The following is a description of a gene set: IL-10 or IL-6 stimulation of control 129xC57BL/6 murine bone marrow derived macrophages in the presence of LPS. We used microarrays to detail the global programme of gene expression changes in response to IL-6 or IL-10 stimulation in the presence of lipopolysaccharide. BMDMs were isolated from control, IL-6-/-, and IL-10-/- mice on a 129XBL/6 mixed background mice and differentiated in the presence of CSF-1 for 6-7 days. Cells were scraped and plated in 6 well plates at 2x10e6/well. Cells were washed with complete DMEM and rested for 1-2 hr before stimulation with combinations of IL-10 (10 ng/ml), IL-6 (2 ng/ml) or LPS (100 ng/ml) for 45 min or 180 mins. Complete biological replicates were performed. species: Homo sapiens from publication El Kasmi KC, Holst J, Coffre M, Mielke L, de Pauw A, Lhocine N, Smith AM, Rutschman R, Kaushal D, Shen Y, Suda T, Donnelly RP, Myers MG Jr, Alexander W, Vignali DA, Watowich SS, Ernst M, Hilton DJ, Murray PJ (PMID 17114459) Human Gene Set: GSE5589_UNSTIM_VS_45MIN_LPS_AND_IL6_STIM_MACROPHAGE_UP Genes up-regulated in bone marrow-derived macrophages: untreated (0 min) versus IL6 and LPS (45 min)., and this is the list of marker genes: INPP4A, PBRM1, TUG1, MOB2, PNISR, SPEN, PHF14, MPST, ZXDC, BACH1, MLEC, IFT25, KLF6, PLPP2, RCBTB2, FILIP1L, PAFAH1B3, TRPS1, DOCK3, MIGA1, PARP3, LRP5, PARP8, LMO2, PIK3CG, NFIA, DYNLT1, PTPRC, KCNJ10, SLC11A1, PIK3IP1, ABTB1, RDH10, SURF4, HPS4, HNRNPUL1, MRPS18C, MTMR14, AMBRA1, PKIB, OLFML3, KLF2, HSCB, ENTPD4, DMXL2, TAL1, SLC6A6, FRY, ING1, ASPSCR1, CIR1, CANX, CYSLTR1, CYTH1, CDC25B, TMEM176B, RNF135, AKNA, KHK, RRM1, PTK2B, SNHG3, RAB32, VPS54, HSDL1, IFT140, SMAD6, WBP1 (NCBI Gene Id 96445), MRPL18, TNFRSF13B, ZFP90, RPL23A, EXOC4, MLF2 (NCBI Gene Id 8079), XPA, CLASP2, SNX20, MCOLN3, ORC3, MRPL39, AGO1, SHCBP1, RERE, KLHL17, NDST2, SLC16A10, DEPTOR, ZCCHC8, MOB3C, UTP14A, MBNL3, VPS26C, TBCEL, FBXW9 (F-box and WD repeat domain containing 9, NCBI Gene Id 84261), CDC26, STMN1, CAMK1, CTDSP1, SNAPIN, AAK1, RMND5B, RASA4, G6PD, MON2, ALDH2, GNPDA1, GRB2 (NCBI Gene Id 80715), CCDC12, CYTH3, BIRC2, PSENEN, APBA1, SLC12A2, R3HDM4, LAMP1, FXR1, NPRL2, FAS, VGLL4, RTL5, SAMSN1, PHF7, RNF145, ABCC1 (ATP binding cassette subfamily C member 1 (ABCC1 blood group)), FCGR2A, CTSC, TEF, MSH2, LCORL, PFDN5, DUSP7, MAGED1, MTURN, ERLIN1, TRIM21, PLCB3, PIK3C2A, MEF2A, PEX10, EPB41L3, HMG20A, SESN1, ZMAT2, GAB3, CD86, MED22, NRM, PDXK, ENC1, RAB20, NEURL1B, REXO2, CASP8, ATP8B2, PPM1D, FLOT1, MFSD1, ARHGAP11A, IL4R, DYRK2, C1QC, ZNF524, PTPN22, ARHGAP17, CALHM6, TMEM106C, NDUFA4, FNBP4, TNNC1, PARPBP, FKBP1B, PRIMPOL, RABEP2, COMMD4, BMP2, GPR183, GALNT2, SNAP23, ARID5A, TIMM10B, RPS6KA1, UAP1, NTAQ1, MAPKAPK2, SSH3, GPR160, C12orf57, GLT8D1, HPS3, ARHGAP22, DCTPP1, OSBPL3, KIAA0513, GMNN, LSP1, LPIN2, WDR24, PPT1, AKAP10, SIRT3